The following is a description of a gene set: species: Homo sapiens Human Gene Set: REACTOME_AUF1_HNRNP_D0_BINDS_AND_DESTABILIZES_MRNA AUF1 (hnRNP D0) binds and destabilizes mRNA, and this is the list of marker genes: PSMD2, HNRNPD, PSMD6, HSPB1, PSMD13, PSMB1, PSMC4, HSPA1A (heat shock protein family A (Hsp70) member 1A), PSMD12, PSMA3, PSMB2, UBC, PSMA5, PSMA4, PSMC1, PSMD3, EIF4G1, UBB, PSMB7, PSMD8, UBA52, PSMA7, HSPA8, PSMA6, PABPC1, PSMC6, PSMC5, PSMC2, PSMD11, PSMA1, RPS27A, PSMD14, PSMB3, SEM1, PSMB5, PSMB6, PSMD1, PSMC3, ADRM1, PSMD7, PSMA2, PSMB4